Given this list of marker genes UBB, UBC, E, UBA52, RPS27A, here is a description of the gene set: Reactome Pathway: Maturation of protein E_9694493 species: Homo sapiens part of: Translation of Structural Proteins This COVID-19 pathway has been created by a combination of computational inference from SARS-CoV-1 data (https://reactome.org/documentation/inferred-events) and manual curation, as described in the summation for the overall SARS-CoV-2 infection pathway.<br><br>The envelope protein (E) gets palmitoylated and ubiquitinated after translation. It forms trimers that show porin activity but does not localize to the cell membrane